The following is a description of a gene set: studied in species Mus musculus Mouse Gene Set: GOCC_METHYLTRANSFERASE_COMPLEX A protein complex that possesses methyltransferase activity., and this is the list of marker genes: Taf7, Snrpe, Riok1, Dnmt3l, Snrpd2, Wdr5b, Kat8, Ezh2, Zfp335, Paxip1, Snrpd3, Snrpg, Clns1a, Mettl3, Aebp2, Bod1, Prdm4, N6amt1, Trmt112, Taf6, Phf19, Hdac2, Taf9, Setd1a, Rnf2, 0610010K14Rik, Trmt6, Dydc1, Setd1b, Mcrs1, Rbm15, Jarid2, 9630013A20Rik, Kmt2a, Cxxc1, Ramacl, Senp3, Ncoa6, Evx1os, Wdr77, Wtap, Snrpert, Sirt1, Suz12, Taf4, Rbbp7, Erhrt-ps, Erh, Chaer1, Thumpd2, Snrpb, Kdm6b, Snrpf, Zc3h13, Prpf31 (pre-mRNA processing factor 31), Hoxb5os, Wdr5, Cbx5 (NCBI Gene Id 97945), Phf1 (PHD finger protein 1), Rbm15b, Trim37, Rbbp4, Taf1, Ezh1, Mtf2, Las1l, Gnmt, Phf20, Trmt10c, Prdm8, Virma, Hcfc1, Kmt2d, Hsd17b10, Mettl1, Snrpd1, Max, Ramac, Men1, E2f6, Hcfc2, Pelp1, Kmt2c, Pagr1a, Trmt61a, Chd8, Bod1l, Mettl14, Kansl1, Prmt5, Trmt11, Ino80c, Ruvbl2, Rbbp5, Nsd1, Hdac9, Epop, Wdr82, Kdm6a (lysine (K)-specific demethylase 6A), Wdr4, Ruvbl1, Eed, Cbll1, Kmt2b, Dpy30, Mga, Ash2l, Rnmt, Prmt1, Uty, Tex10